Given this list of marker genes TAFA4, CHRM1, PTPN1, PLEKHA5, ERBIN, EGLN1, NSG2, OGT (O-linked N-acetylglucosamine (GlcNAc) transferase), GNAO1, GRID1, CADPS2, SPTBN1 (spectrin beta, non-erythrocytic 1), NRN1 (neuritin 1), CLCN3, PPFIA3, FXR1, CPNE4, TENM4, RNF220, CNR1, THY1, UBE3B, SRCIN1, GRM2, PPP1CC, LGI1, ACTBL2 (actin beta like 2), YWHAH, ARF6, PAK2, ABHD17C, FABP5, CBLN4, ARHGEF15, FAAH, MOB4, BSN, IL1RAPL1, C1QBP, APBA1, DRD4, MAP1LC3A, ITPKA, HTR4, DOC2A, TNC, JAK2, FLNA, PCDH10, SIGMAR1, LINGO2, C1QC, SYN3, RNF10, SIPA1L3, ARHGAP33, NPTX2, EPHB2, SORCS3, PRRT2, SLC1A6, LRRTM2, PACSIN2, EIF4A3, SQSTM1, LPAR1, CORO1B, PIN1, HIP1R, RGS7, ATP2B2, DAAM1, NGEF, NETO1, ADRA2A, SYT1, SUMO1, ITGB1, RAB4A, NAPA, PRKAR1A, NCKIPSD, FLRT2, ERBB4, APPL1, PIAS1, MAP1B, AGAP3, MLF2, PPP3CC, HOMER2, CUL3, SEMA4C, EHD1, EEF2K, DIXDC1 (DIX domain containing 1), FARP1 (NCBI Gene Id 10160), UBE2I, RTN4, BIN1, FGFR1, RAB17, ARC, LRRC4, TFRC, ZDHHC8, ADORA2A, CNRIP1, LATS1, LIN7C, GABRR1, RPS6KB1 (ribosomal protein S6 kinase B1), ATP2B3, ADAM10, PCDH17, ABHD17B (abhydrolase domain containing 17B, depalmitoylase), SYNPO, NEDD4, SHROOM4, RGS9, FLOT2, GRIN2A, ITSN1, GUCY1B1, VAPB, CNKSR2, KPTN, PARN, RAB11A, SHANK1, SH3KBP1, SUMO2, PAFAH1B1, ABHD17A, DLG5, NOS1AP, HIP1, CBLB, NRG3, ARHGAP39, SLC30A3, DLG3, FXYD6, CACNB4, VCP, NEURL1, PORCN, PPP2R2A, RABEP1, TSPOAP1, STX1A, DLGAP1, VASP, LIMK1, KCNA2, PRKACA, CALB1, AGO2, DOCK4 (dedicator of cytokinesis 4), CRELD1, SIPA1L2, ARPC1A, RAB8A, RPS27, ADAM23, EPS8, LYN, PPP3CB, EFR3A, SARM1, HNRNPD, ARHGAP44, RYK, C1QL1, ICAM5, DRP2, NUDT3, TNIK, LRRC4B, ZDHHC17, ARFGEF2, SOS1, ARHGAP12, SCN10A, PPP1CA, CORO1A, PDE10A, RPL22 (ribosomal protein L22), SRPX2, PRSS12, NLGN4Y, PRKCI, CDH8, NEDD8, STAT3, ANP32E, NETO2, GRIK3, WASL, DAPK1, NTN1, SNX27, CARMIL3, HTR2A, PLXND1, ABL1, PLG, MAPK14, ELFN1, LRFN4, EPHA7, ARRB2, CNNM2, LRFN3, CACNG8, VPS18, CLSTN3, PPFIA2, MAPK3, C1QA, SPTB, EPB41L3, AURKA, FILIP1, NLGN1, BRINP1, SRGAP2C, WNT3A, CNTN1 (contactin 1), PFN1, RMDN3, SH3GL2, CDH1, STX3, ZDHHC5, PCDH9, CACNG4, WNT7A, ELMO1, EFNB1, SEMA3A, CSPG5, SNAP25, SLC1A2, OSBPL2, CSMD2, PLXNA4, PRUNE2, DNAJB1, C1QL3, GHSR, BCAN, ATP8A1 (ATPase phospholipid transporting 8A1), ACTN2, CALR, SYT4, FBXO2, GPM6A, RAP1B, DRD1, ALS2, PRRT1, ZDHHC2, NAE1, BTBD9, AKT1, CTBP1, RASGRF2, SNX6, NRGN, CDH6, ADORA2B, DYNLL2, SLC17A8, HPCA, C1QL2, RAB7A, CHMP2B, SRGAP2, APOE, PHF24, PSEN1, PRR7, FZD3, PLPPR4, ATAD1, DBN1, BCR, ABLIM3, EFNB3, ABTB3, ADGRL3, UBE2M, RGS14, NTRK3, WNT5A (Wnt family member 5A), VAMP4, RABAC1, PSD2, UBE3A, PJA2, RAP1A, SRGAP2B, VANGL2, GRIP2, CACNG7, DLG1, CNTNAP1, GRM1, PLXNB1, ACP4, NRXN2, GPC4, PLXNA1, CDH10, CNTNAP2, CRHR1, LZTS1, CRIPT, NRCAM, ITGA8, AKAP9, ITGB3, CASKIN1, TMEM240, USP6, DTNBP1, PGRMC2, SHISA9, MRTFB, RHOG, KIFAP3, STAU2, SLC17A5, KCNJ8, CDC42, HOMER3, SYT17, DGKI, AP2M1, EIF4E, PRKAR1B, IL1RAP, GUCY1A1, VWC2, PAK3, ABR, SLC6A17, FGF22, CADPS, HOMER1, BAIAP2, CBLN1, SLITRK2, KCND2, SV2A, PTK2B, WASF3, CDH11, PLCB1, C9orf72, USP14, EEA1 (early endosome antigen 1, NCBI Gene Id 8411), DAB1, NTNG1, NF1, NLGN4X, EPHB1, MARK1, CPSF2, LRRTM3, ARPC5L, ARHGAP22, OPHN1, STAU1, TNR, DISC1, GSK3B, MYH10, CNIH3, CACNG2, EFNB2, ATG16L1, MIB1 (NCBI Gene Id 57534), GHRL, PPP1R9B, ARPC2, CTNNB1, BRAF, ASIC1, CASP3, CLASP2, ADCY8, PURA, CFL1, FAM81A, AP2A1, CLSTN1, NRXN1, AMOT, CC2D1A, ACTB, RTN4R, PPM1H, DRD2, AP3D1, PPP2R1A, NPTXR, STXBP1, DGKE, CLSTN2, KPNA1, FLRT3, SPARCL1, GRIN2C, FBXO45, LRFN5, NPY2R, DAG1, PTPRD, PRICKLE1, FLOT1, GRID2IP, GRM3, SLC16A7, ATP2B4, GRIK2 (NCBI Gene Id 2898), CACNG5, GRIPAP1, VPS26B, GRN, LAMA5, NRP2, ELAVL1, GIPC1, RELA, EPS15, PPP3R1, SLC4A8, SLC12A5, DPYSL5, RAC3, NRP1 (neuropilin 1), CRTAC1, IL1RAPL2, DLG4, WDR1, FZD4, DROSHA, PIK3C3, KIF3B (kinesin family member 3B), NEO1, LRP8, SH3GL3, RHOA, GRID2, SENP1, DSTN, GSG1L, SEMA3F, EPHA4, LPAR2, AP2B1, ABI3, ADGRA1, PPP3CA, TRIM47, CTTNBP2, CPT1C, P2RX1, NCDN, PI4K2A, SACM1L, RGS7BP, PIAS3, CASR, GRIN2D, CHD4, CDKL5, CPLX2 (NCBI Gene Id 84242), SHISA6, NOTCH1, NUMB, NXPH1, GABBR1, IGSF9, SH3GL1, PUM2, USP46, NTNG2, YWHAZ, TMEM108, KCNJ2, NLGN3, DVL1, CBLN2, CAP1, DLGAP3, KIF2C, STK38, PRKAR2B, ADGRB3, NSG1, DLGAP2, TAMALIN, DGKQ, FUS, SLITRK4, PCLO, CALY, ADCY1, TANC1, PRAF2, GRIN3A, ELMOD1, NPTX1, SLITRK1, ACTC1, LRRC4C, CTTN, CAMKV, PFN2, SYNGAP1, NAPB, S1PR2, FYN, PLAT, EEF2, LRRK2, PRKN (NCBI Gene Id 8004), ERC2, ATP2B1, SYN2, PCDH8, SYNDIG1, TRAF6, PTPRO (NCBI Gene Id 5800), NUMBL, ACTN1, TRIO, SEMA4F, HCN1, GABRD, VPS35, GRIA1, USP8, SEMA4B, DLGAP4, HRAS, STRN4, VLDLR, CPLX1, DBNL, FBXL20, DOCK10 (dedicator of cytokinesis 10), AP3M2, ATG5, GIT1, PTPRS, GRM5, SYT10, ADGRB2, SHISA7, SLITRK5, ITGA3, SORT1, STX4, MDM2, ARF4, CACNG3, SPTBN2, ABHD6, RAC1, MAP2K1, P2RY1, SCRIB, NRG1, P2RX6, DOCK1, ITGA5, PDXP, DGKZ, DGCR8, PLXNC1, IGF1, here is a description of the gene set: species: Homo sapiens A synapse that uses glutamate as a neurotransmitter. Human Gene Set: GOCC_GLUTAMATERGIC_SYNAPSE